The following is a description of a gene set: electronically inferred by orthology from the curated human pathway species: Mus musculus Reactome Pathway: Interaction of NuRD complexes with transcription factors part of: NuRD complex assembly This event has been computationally inferred from an event that has been demonstrated in another species.<p>The inference is based on the homology mapping from PANTHER. Briefly, reactions for which all involved PhysicalEntities (in input, output and catalyst) have a mapped orthologue/paralogue (for complexes at least 75% of components must have a mapping) are inferred to the other species., and this is the list of marker genes: H4c18, H3c4, Nr2c2, Rbbp7, Zfp687, Mta2, H2ac15, H3c10, H2az2 (H2A.Z histone variant 2), H4c6, H2bc3 (H2B clustered histone 3), H3c7, H2ac6, H2ac8, H2ac22 (NCBI Gene Id 319170), H2ac13, H2bc8, H4c11, H3f3a, H4c1, Mta1, H3c13, Mbd2, H4c4, H2ac7, H2ac12, H2bc1, H3c1, H2bc27, H2ac10, H4c9, H2ac19 (NCBI Gene Id 319192), Mbd3, H4c8, H3c8, H4c2, H3c15, H4c3, H3c3, H3c2, H2bc12, H2ac23, H2ac4, H2bc7, H3c6, H2ac20, H4c12, H2ac11, H2bc9, Rbbp4, H2ac24, H3c11, H4c17, H2ac1, H2bc22, H4c14, Zfp532, H2bc11, H2ax, H2bc13, H2bc15